Given this list of marker genes Stau1, Dynlt1c, Tbc1d20, Dynlt1f, Dynlt1a, Vapb, Hacd3, Ddb1, Stat1, Dynlt1b, here is a description of the gene set: Any virus-mediated process that modulates the levels of viral proteins in a cell. Mouse Gene Set: GOBP_REGULATION_BY_VIRUS_OF_VIRAL_PROTEIN_LEVELS_IN_HOST_CELL species: Mus musculus